Given this list of marker genes MYLK, ADORA3, TOM1L2, EPN3, PPP1R16B, FLOT2, POLR3E, LARGE1, MYO6, ZRANB1, ZNF765 (NCBI Gene Id 91661), FBXL7, DLAT, KLHDC10, SERPINB12, ABCD2, SV2B, ABTB3, RAB3D, RGS14, USP3, RBFA, CAMTA2, ZNF662, MAB21L3, MEIS2, SMTN, YWHAH, RAB6B, NAA25, PPFIA2, SCAMP1, GNAT1, CDH13, MED1, TMOD2 (tropomodulin 2), ING3, YLPM1, PTGER3, RNF138, SARS1, ACVR1C, WDR90, NKX2-1, DIRAS2, HS3ST4, VAT1L, MAPT, MR1, TFDP1, REG3A, CCDC91, CTXN3, KLF3, CAMK2G, PCNX1, CDHR4, ZNF550, HIPK3, FBXO41, TOP2A, MXRA7, MS4A3, FLG2, here is a description of the gene set: Genes predicted to be targets of miRBase v22 microRNA hsa-miR-4641 in miRDB v6.0 with MirTarget v4 prediction scores > 80 (high confidence targets). Human Gene Set: MIR4641 species: Homo sapiens from publication Chen Y, Wang X (PMID 31504780)